The following is a description of a gene set: Enables the transfer of sulfate ions, SO4(2-), from one side of a membrane to the other. studied in species Mus musculus Mouse Gene Set: GOMF_SULFATE_TRANSMEMBRANE_TRANSPORTER_ACTIVITY, and this is the list of marker genes: Slc26a9, Slc26a10, Slc13a4, Slc26a3, Slc26a11, Slc26a6, Slc26a7, Slc25a10, Slc26a2, Slc26a4, Slc13a1, Slc26a1, Slc26a5 (NCBI Gene Id 80979), Slc26a8, Ucp2